Given this list of marker genes Ahr, Sohlh1, Lfng, Scaper, Zp3, Gpr149, Bmp4, Smad4, Nr5a2, Spo11, Kdr, Ermp1, Mfn2, Eif2b5, Dmrta1, Fshb, Adrm1, Amh, Bcas2, Nppc, Esr2, Atm, Npr2, Inha, Bax, Adcyap1, Eif2b2, Nobox, Msh4, Umodl1, Kit, Mmp14, Vegfa, Angpt1, Mmp2, Inhba, Mmp19, Oas1d, Taf4, Lhb, Dmc1, Eif2b4, Fancg (NCBI Gene Id 60534), Cebpb, Vgf, Fgf7, Fance, Foxo3, Kitl, Fancf, Rac1, Foxc1, Fshr, Ube3a, Lsm14b, Myh9, Sod1, Ptger4 (prostaglandin E receptor 4 (subtype EP4)), Sohlh2, Esr1, Gas2, Ptx3, Pcyt1b, Bmpr1b, Hnrnpk, Kmt2b, Phb1, Grk2, Bcl2, Bcl2l1, Immp2l, Lhcgr, Ereg, Arrb1, Arrb2, Hyal3, Ctnna1, Gnrh1, Zfx, Tnfaip6, Foxl2, Zfp830, Src, here is a description of the gene set: studied in species Mus musculus Mouse Gene Set: GOBP_OVARIAN_FOLLICLE_DEVELOPMENT The process whose specific outcome is the progression of the ovarian follicle over time, from its formation to the mature structure.